Given this list of marker genes CYTH1, TUBA4A, INA, LAMA5, LZTS3, MYH11, DSP (NCBI Gene Id 202512), CENPF, KRT17, CDC20, CORO1A, KRT14, BIRC5, DTNB, SH3GL2, FAM107A, DYNC1I1, SNAP25, KRT6A, CENPE, KIF5A, TNC, KRT6B, CCNT1, KRT5, KIF11, ACTR1A, TUBB4A, AMPH, KIF2C, GAS7, TACC2, TRIM13, KIF5C, KRT2, ACTR1B, STMN1, VAMP2, MYH7, ZWINT, PALM, MAP2, STMN2, NUMA1, KRT19, LAMC2, NEFL, KRT7, KRT4, LAMB1, SFTPD, KLC1, SNPH, KRT13, SEPTIN4, PKP4, LMNB1, HIP1, KIF23, OCLN, SEPTIN5, STX1A, EVPL, LAMA3, MAPT, ARHGAP4, KRT8, MID1, here is a description of the gene set: studied in species Homo sapiens Intermediate filaments and MT. Human Gene Set: MODULE_438